Given this list of marker genes Scd4, Acsl3, Cyp7a1, Pla2g3, Acox2, Hsd17b4, Alox5, Prkar2b, Auh (AU RNA binding protein/enoyl-coenzyme A hydratase), Acat1, Elovl1, Cyp4f40, Rgn, Twist1, Hadh, Acot1, Fmo2, Akr1c20, Akr1b7, Insig1, Ech1, Dcaf5, Enpp1, Ucp3, Mblac2, Klhl25, Acot2, Akr1c6, Ephx1, Abcb11, Nudt7, Pex5, Alox12e, Alox12b, Cygb (NCBI Gene Id 78886), Lipc, Acnat1, Slc27a4, Ces1h, Mcat, Cyp2j11, Elovl3, Akr1b1, Cyp2j7, Sirt2, Lpgat1, Them5, Pecr, Pibf1, Lpin1, Acad9, Prkab1, Gk, Asah1, Alox15, Aoah, Cyp2j9, Scp2, Cyp2c37, Tecrl, Acadsb, Cyp4f15, Tyrp1, Tysnd1, Hacl1, Acss1, Ces2h, Anxa1, Pdk2, Kat2b, Decr1 (2,4-dienoyl CoA reductase 1, mitochondrial), Cpt2, Cyp2c55, Mecr, Apoc2, Acoxl (NCBI Gene Id 99258), Ubr4, Acsf2, Gdf15, Scd3, Degs1, Pla2g5, Pex13, Hao2, Akr1c21, Elovl7, Apoa4, Acly, Dbi, Peds1, Plp1, Acsf3, Ptgr1, Ces2g, Akr1c13, Dgat1, Elovl5, Cryl1, Ppara, Comt, Etfdh, C1qtnf2, Tnxb (NCBI Gene Id 81877), Acacb, Irs2, Ptgs1, Cyp2c29, Gstm6, Cyp4f18, Thnsl2, Cyp2b19, Baat, Gip, Pck1, Ces2c, Ces1c, Edn2, Asah2, Lipe, Adipor1, Cyp2a5, Mapk14, Tmem135, Hacd1, Cav1, Gstp2, Abhd1, Adtrp, Cyp2s1, Olah, Akr1c14, Crot, Cyp2c38, Cyp2d10, Acsm1 (NCBI Gene Id 117147), Nucb2, Mtln, Naaa, Ptgis, Scd1, Mgll, Prkag3, Eci2, Slc27a3, Acsm4, Hsd17b8, Slc27a5, Abhd2, Abcd2, Cyp2d12, Apoc3, Akt2, Apoa5, Ndufab1, Aldh3a2, Cyp2f2, Ptges2, Prkaa1, Edn1, Cyp2d34, Abcd4, Cyp2d26, Abcd1, Ndufs6, Cthrc1, Aloxe3, Cyp2b10, Mir199a-2, Plaa (phospholipase A2, activating protein), Gstm2, Acot4, Ces1f, Pdk4, Bdh2, Lypla2, Lipg, Gpx1, Ephx2, Pnlip, Erfe, Pla2g2a, Cyp4a14, Cyp2j8, Slc25a17, Lypla1, Amacr, Eci1, Sesn2, Myo5a, C3, Gpat4, Etfbkmt, Cyp2a22, Per2, Pdk1, Cyp2t4, Pex2, Pam, Insig2, Elovl2, Acad10, Acot12, Pla2g15, Acaa1b, Ahr, Gcdh (NCBI Gene Id 97486), Nr1h3, Erlin1, Hnf1a, Cyp2d11, Gstp3, Mir214, Mif, Cpt1a, Acsl1, Akt1, Acsbg2, Echdc1, Ptges3, Pck2 (phosphoenolpyruvate carboxykinase 2 (mitochondrial)), Gstm3, Aldh1l2, Cd74, Gpx4, Cyp4a12a, Cyp2d9, Trib3, Adh5, Bckdk, Ceacam1, Mlycd, Cyp2c50, Ces1e, Sirt4, Cyp4f14, Cyp2j13, Daglb, Snca (NCBI Gene Id 20617), Acot9, Sco1, Cyp2c23, Cyp2b9, Pla2g10, Nfe2l1, Ceacam2, Hadhb, Abcc9 (NCBI Gene Id 58900), Acbd7, Lipa, Slc27a6, Ggt5, Ncor1 (nuclear receptor co-repressor 1), Akr1c18, Slc45a3, Eci3, Acadl (acyl-Coenzyme A dehydrogenase, long-chain), Abhd3, Cpt1c, Trex1, Plin5, Apoc2l, Cyp4v3, Fads1, Cyp1a1, Cyp2e1, Angptl3, Fabp5, Gstm7, Them4, Fads2b, Pla2g4a, Alox5ap, Eif2ak3, Aacs, Ces2e, Sgpl1, Acaa1a, Slc27a1, Adipor2, Cyp4f13, Ces1b, Alox8 (arachidonate 8-lipoxygenase), Il1b, Lpl, Fads3, Acss2, Acsl4, Acsbg3, Hpgd (NCBI Gene Id 234274), Gstm1, Acsl6, Pnliprp2, Ces2f, Acnat2, Hpgds, Fads6, Acot3, Brca1, Pm20d1, Acsm2, Echdc2, Abcd3, Pank2, Sphk1, Gstm4, Pnpla8, Dld, Sox9, Hnf4a, Pdk3, Slc22a13, Sirt1, Cyp2a4, Cyp1b1, Crat, Ins2, Th, Ankrd23, Adh4, Fabp4, Tnfrsf1a, Fabp1, Ltc4s, Lonp2, Acsm5, Bmncr, Wdtc1, Acot5, Decr2, Dbil5, Hao1, Mmut, Cyp4a30b, Cyb5a, Cyp2c54, Ppard, Irs1, Obp2a, Cyp2u1, Hacd2, Dgat2, Appl2, Blvra, Cyp1a2, Slc27a2, Ghsr, Ptges, Fa2h, Ces1a, Fabp3, Srebf1, Echdc3, Por, Etfa, Avp, Ptgs2, Cyp4a12b (cytochrome P450, family 4, subfamily a, polypeptide 12B), Hsd17b12, Fasn, Akr1c19, Cpt1b, Cyp4a31, Acat2, Fads2, Echs1, Pla2g4d, Lpin2, Scap, Mlxipl, Eif6, Ilvbl, Fmo4, Cyp2a12, Pla2g2f, Ces2a, Dagla, Phyh, Mfsd2a, Cyp4a29, C1qtnf9, Elovl4, Pnpla3, Mtor, Ptgds, Akr1c12, Tbxas1, Ankrd26, Lias, Acad12, Acsbg1, Elovl6, Qki, Avpr1a, Cnr1, Pla2g1b, Pparg, Acads, Cyp4a10, Adh7, Prkag1, Mgst3, Prkag2, Etfb, Cyp2b13, Cyp2g1, Acad11, Nudt8, Abhd5, Gstp-ps, Hacd4, Acbd5, Cyp4a32, Acox1, Hsd17b10, Lep, Tecr, Faah, Cyp2c39, Atp6v1b1, Cbr4 (NCBI Gene Id 338511), Fmo1, Apoc1, Ptges3-ps, Mapk9, Acot7, Gsta1, Ces1d, Gstp1, Lpin3, Ces1g, Cyp2j6, Alkbh7, Pnliprp1, Cyp2j12, Cp, Ces2b, Alox12, Pgk1, Adipoq (adiponectin, C1Q and collagen domain containing), Prkaa2, Gpam, Erlin2, Oxsm, Agt, Acaa2, Acot6, Aasdh, Ppargc1a, Pex7, Mid1ip1, Ivd, Cyp2d22, Hacd3, Acadm, Hadha, Acadvl, Fabp2, Tpk1, Acot8, Ehhadh, Cyp2c40, Acsm3, Aig1, Scd2, Acaca, Pdpn, Acsl5, Htd2, Acox3, Pla2g4f, Cyp2j5, Akr1cl, Prkab2, Nr1h2, Nudt19, Prxl2b, Acot11, Ptgr2, Mcrip2, Cyp2b23, Ins1 (insulin I), here is a description of the gene set: The chemical reactions and pathways involving fatty acids, aliphatic monocarboxylic acids liberated from naturally occurring fats and oils by hydrolysis. Mouse Gene Set: GOBP_FATTY_ACID_METABOLIC_PROCESS studied in species Mus musculus